Given this list of marker genes NEFL, PPP1R2, CRIP1, YIPF5 (Yip1 domain family member 5), GLI2, PPP1CC, LIMS1 (NCBI Gene Id 3987), UXS1, RAD21, PRPF39, ARHGAP15, IL1R1, PGRMC1, TIMP1, PKP4, UPF3A, CREBL2, CMPK1 (cytidine/uridine monophosphate kinase 1), ELOVL5, H2AC4, TRIM16, SFN, TNKS2, YWHAZ, TAB2, PNMA1, ZFX, XRCC6, CBR3, TRAT1, TSPYL1, NCF4, LRIG1, SYNE3, SLC30A5, DEGS1, USP10, ISCA1, MFHAS1, CNBP, GPR15, N4BP2L2, PSMA1, BAMBI, MBNL3, WTAP, TNFRSF4, DEK, LPAR6, ORC2, GGT1, CRTAP, AIDA, SEPTIN9, EID1, NCK2, CR1, WDR76, ZFP36L1, TMEM123, TCTN2, ITGB7, RBL1, ZFR, LDHA, ARF6, CDC5L, UNG, ST8SIA1, EHD4, BMPR1A, CORO1B, PDIA3, EVI2B, FOXN2, TP53BP2 (NCBI Gene Id 7159), HIVEP2, PLP2, G3BP1, HEBP2, SNX15, ERN1, CBFB, CD44, ITM2B, YWHAB, SUSD6, NFYC, ICAM2, CD40LG, AGFG2, FBXO34, ENOX1, SLC39A8, CALM1, MDFIC, EPHA4, ERO1A, DSTNP2, ACP5, SEPTIN10, HNRNPF, PPP6C, ACVR1, DSTN, ATP8B2, TSPAN5, SESN1, NAP1L2, UBE2E1, CCR9, ELK3, STAT5B, PDS5A, AHR, PTGES3, GTPBP3, UBR7, IL17RB, CD28, SUMO2, EIF5A, MATR3, TAGLN2, TRAM1, CCR6, IL6R, PBXIP1 (NCBI Gene Id 57326), KRT33A, CITED2, GOLGA7, HNRNPA0, JRKL, SAMSN1, MUC2, CCDC47, NUP62CL, PHTF2, CAB39, MTRR, CAPG, KCMF1, CD47, TUFT1, CBLL1, FLI1, RAD23B, CCR4, VPS33A, KDM4C, BIRC3, DNAJA2 (DnaJ heat shock protein family (Hsp40) member A2), RASGRP1, ACAP2, TRADD, AQP3, RPL39L, TRAPPC3, DOCK9, CHN1, RAP1A, SEC31A, LMBRD1, HIRA, GSR, INPP4B, SLAMF1, GATAD2A, GRK6, IVNS1ABP, IFT57, NR2F6, GLOD4, FUT7, TPMT, TNFSF10, TMOD3, HECA, RCBTB2, GPR25, EDEM1, MEOX1, MEX3C, REEP4, ALCAM, EIF4EBP2, FRMD4B, PRELID3B, CCND2, CASP2, DUSP7, FBXL8, KIAA0040, FAM117A, CCR10, CLMN, TEX14, DAZAP1, EIF4G2, here is a description of the gene set: Immune cell-specific expression is one indication of the importance of a gene's role in the immune response. In order to identify such patterns, we set out to broadly profile gene expression in a variety of immune cells. from publication Abbas AR, Baldwin D, Ma Y, Ouyang W, Gurney A, Martin F, Fong S, van Lookeren Campagne M, Godowski P, Williams PM, Chan AC, Clark HF (PMID 15789058) Genes down-regulated in comparison of naive CD4 CD8 T cells versus unstimulated memory CD4 CD8 T cells. Human Gene Set: GSE22886_NAIVE_VS_MEMORY_TCELL_DN studied in species Homo sapiens